Given this list of marker genes CD8B, CLTA, CISD2 (CDGSH iron sulfur domain 2), CCR5, HNRNPA3P1, PGAP1, RFK, MRPS24, DDB2, FABP5, IGFLR1, BORA, NUDCD3, GMEB1, PSMD13, ATOX1, PPP1R7, SEM1 (SEM1 26S proteasome subunit), PBDC1, CD81, SKA2, CD96, RACGAP1, SLC11A2, MYO7A, WDR54, TIGIT, RALA, GZMB, DIABLO, MIF4GD, SLC43A3, ANAPC11, MCM5, HCFC1R1, C1QB, TPI1, CTSL, COX5A, ILVBL, GPR137B, THYN1, ENSG00000187951, CYB5A, TUBB4B, TCF12, ADAP2, PCK2, DUSP16, SDHAP3, CENPX, USP11, MT1E, GNLY, MED27, MIR155HG, PSMC1, IRAK1, SNAP47, SUPT16H, TMED9, CUEDC2, CD3D, GGA2, CBLB, RTL6, HCST, LCMT1, ZWILCH, N4BP2 (NEDD4 binding protein 2), PSMD14, PSMB2, SLAMF8, NTAN1, KLRC1, CTSC, TIMM23, AKR1A1, GNA15, TBL2, ACP5, AMBRA1, HAVCR2, CLPTM1L, MDC1, PHYH, PGRMC2, CNDP2, SDC4, RBBP8, DCP1B, PSMD2, CHID1, COPS8, NANS, MICALL1, SERPING1, CTSB, SLC35B2, RAB13, PLIN2, SOD1, PDE4A, MRPL57, ASMTL, MT1F, PAIP1, ZNF426, ZNF410 (zinc finger protein 410), ETFB, SYTL3, C1QC, SLC1A4, TNFAIP3, SNX9, GALNT2, ALDH6A1, SYT11, EOLA1, CRIP1, CHTOP, CHCHD3, SNX5, SDHA, CD86, ATF5, SMIM12, EHD4, CDKN1A, NUP37, FLVCR2, MRPL9, CPSF3, GCHFR, BOLA2, COQ5, CKS2, here is a description of the gene set: Stevens-Johnson syndrome (SJS) and toxic epidermal necrolysis (TEN) are life-threatening adverse drug reactions characterized by massive epidermal necrosis, in which the specific danger signals involved remain unclear. Here we show that blister cells from skin lesions of SJS-TEN primarily consist of cytotoxic T lymphocytes (CTLs) and natural killer (NK) cells, and both blister fluids and cells were cytotoxic. Gene expression profiling identified granulysin as the most highly expressed cytotoxic molecule, confirmed by quantitative PCR and immunohistochemistry. Granulysin concentrations in the blister fluids were two to four orders of magnitude higher than perforin, granzyme B or soluble Fas ligand concentrations, and depleting granulysin reduced the cytotoxicity. Granulysin in the blister fluids was a 15-kDa secretory form, and injection of it into mouse skin resulted in features mimicking SJS-TEN. Our findings demonstrate that secretory granulysin is a key molecule responsible for the disseminated keratinocyte death in SJS-TEN and highlight a mechanism for CTL- or NK cell--mediated cytotoxicity that does not require direct cellular contact. Human Gene Set: CHUNG_BLISTER_CYTOTOXICITY_UP studied in species Homo sapiens from publication Chung WH, Hung SI, Yang JY, Su SC, Huang SP, Wei CY, Chin SW, Chiou CC, Chu SC, Ho HC, Yang CH, Lu CF, Wu JY, Liao YD, Chen YT (PMID 19029983) Genes up-regulated in blister cells from patients with adverse drug reactions (ADR).